Given this list of marker genes LORICRIN, SCARF2, GLE1, KIT, SMARCD2, C1QC, RNF31, PIGL, CDKN2A, CLPB, GLB1, SKIC3, FAT4, SLC30A9, STAG1, GATA6, HYMAI, STK11, PAK2, GNB2, MDM2, TOP6BL, MYD88, CHEK2, DPF2, CORIN, CDKN1C, CFH, LBR, MYH7, PGAP2, TRAF7 (NCBI Gene Id 84231), VPS35L, HPS6, TBC1D24, F7, NLRP7, SPECC1L, WNT3, SERPINE1, TWIST2, MCTP2, ADGRG6, FANCF, KCNQ1, TAPT1, SPTBN1, ATP6V1B2, PIGV, FCGR3B, PACS1, MKS1, ZNF699, TP63, DDX6, G6PC3, TLK2, LMNA, MAX, KHDC3L (KH domain containing 3 like, subcortical maternal complex member), NRAS, CCDC22, MEI1 (meiotic double-stranded break formation protein 1), TP53, CD46, PLAG1, MUSK, STOX1, PLAGL1, IGF1, CACNA1C, ZMPSTE24, CAPRIN1, THSD1, F13B, WT1, RTL1, PIGO (NCBI Gene Id 84720), PIGY, HNRNPK, KANK2, DPYSL5, QRICH1 (glutamine rich 1), FANCB, FLT1, DLK1, POR, FERMT1, POMP, GJB2, MEG3, FOXF1, RBCK1, ITGB2, IGF2, TRPV3, IL6ST, PHGDH, WASHC5, KCNQ1OT1, PIGW, MTHFS, PGAP3, FGFR3, HMGA2, GJA1, HSPG2, KRT1, CFI, HELLPAR, BCL10, ARPC5, HOXD13, RAC2, SMARCAD1 (SWI/SNF-related, matrix-associated actin-dependent regulator of chromatin, subfamily a, containing DEAD/H box 1), F13A1, here is a description of the gene set: species: Homo sapiens An abnormality of the placenta (the organ that connects the developing fetus to the uterine wall) or of the umbilical cord (the cord that connects the fetus to the placenta). Abnormalities of placenta or umbilical cord Human Gene Set: HP_ABNORMALITIES_OF_PLACENTA_OR_UMBILICAL_CORD